The following is a description of a gene set: An excessive division of the lobes of the nucleus of a neutrophil. Human Gene Set: HP_HYPERSEGMENTATION_OF_NEUTROPHIL_NUCLEI Hypersegmentation of neutrophil nuclei studied in species Homo sapiens, and this is the list of marker genes: MTHFD1, CUBN, SFXN4, FTCD, AMN, SLC19A1